The following is a description of a gene set: species: Homo sapiens Reactome Pathway: Defective SERPING1 causes hereditary angioedema part of: Defects of contact activation system and kallikrein-kinin system  The reciprocal activation is initiated when zymogen factor XII (F12 or FXII) binds to a negatively charged surface, which induces FXII autoactivation. Activated FXII (FXIIa) converts prekallikrein (PK) to kallikrein, which proteolytically liberates bradykinin from high molecular weight kininogen (HK) (Renne T 2012; Renne T et al. 2012; Maas C et al. 2011). Kallikrein also activates FXII to produce more FXIIa (initially). FXIIa and kallikrein reciprocally activate their zymogens and thus generate a positive feedback loop. In the presence of sufficient amounts of active enzyme, FXIIa also generates active factor XI (FXIa) to potentiate the intrinsic coagulation pathway. All of these enzymatic steps are normally inhibited by C1-esterase inhibitor (C1-INH, encoded by the SERPING1 gene).<p>Binding of the proinflammatory peptide hormone bradykinin to the bradykinin B2 receptor (B2R) activates various proinflammatory signaling pathways that increase vascular permeability and fluid efflux. An excessive formation of bradykinin due to uncontrolled activation of the coagulation factor XII (FXII)-dependent kallikrein-kinin system causes increased vascular permeability at the level of the postcapillary venule and results in hereditary angioedema (HAE) (Bossi F et al. 2009; Kaplan AP 2010; Suffritti C et al. 2014: Zuraw BL & Christiansen SC 2016). HAE is a rare life-threatening inherited edema disorder that is characterized by recurrent episodes of localized edema of the skin or of the mucosa of the gastrointestinal tract or upper airway. Angioedema initiated by bradykinin is usually associated with SERPING1 (C1-INH) deficiency. Thus, a major role of SERPING1 (C1-INH) is to prevent the development of excessive vascular permeability. More rarely, HAE occurs in individuals with normal SERPING1 activity, linked to mutations in other proteins, including FXII, plasminogen, and angiopoietin (Magerl M et al. 2017; Zuraw BL 2018; Ivanov I et al. 2019). Patients with HAE are heterozygous for deficiency of SERPING1.The disease, therefore, has an autosomal dominant inheritance and may result from lack of expression of SERPING1 from one allele (type 1 HAE) or from expression of a nonfunctional SERPING1 protein (type 2 HAE). This classification has however been challenged by observations of intermediary HAE types, that can arise, when small amounts of dysfunctional SERPING1 is present in the blood stream (Eldering E et al. 1995; Verpy E et al. 1995; Madsen DE et al. 2014)., and this is the list of marker genes: SERPING1 (serpin family G member 1), F12, KLKB1